Given this list of marker genes IFIH1, RIGI, GBP7, MIR29B1, TLR3, IL32, here is a description of the gene set: Human Gene Set: GOBP_TYPE_III_INTERFERON_PRODUCTION The appearance of type III interferon due to biosynthesis or secretion following a cellular stimulus, resulting in an increase in its intracellular or extracellular levels. Interferon lambda is the only member of the type III interferon found so far. species: Homo sapiens